The following is a description of a gene set: species: Mus musculus Mouse genes annotated to increased circulating tumor necrosis factor level (MP:0008553) retrieved from the Mouse Genome Informatics database via MouseMine Mouse Gene Set: MP_INCREASED_CIRCULATING_TUMOR_NECROSIS_FACTOR_LEVEL from publication Motenko H, Neuhauser SB, O'Keefe M, Richardson JE (PMID 26092688), and this is the list of marker genes: Nlrc3, Tbc1d23, Sod1, Lgmn (legumain), Hmgb1, Flt3, Wwp2, Dusp1 (dual specificity phosphatase 1), Apc, Mavs, Trp53, Ramp1, Marchf2, Tbk1, Cav1, Nod2, Slamf6, Osmr, Il10ra, Itln1, Prdx5, Tlr7, Hmox1, Fasl, Itgal, Map3k7, Tnfaip3 (NCBI Gene Id 21929), Egfr, Ikbkg, Slc2a6, Ash1l, Parg, Snrk, Nfkbia, Wasl, C1qtnf4 (NCBI Gene Id 77240), Sectm1a, Foxp3, Elavl1, Pcsk1, Ncoa3, Sh3bp2, Smpdl3b, Sting1, Hck, Tnf, Il18, Lat2, Traf2, Dusp11, Il10 (interleukin 10), Thbd, Fos, Tnfaip8l2, Tnfrsf1a, Brd2 (NCBI Gene Id 547337), Cyrib, Nfil3, Psmb10, Fitm2, Nfe2l2, Sirt3 (sirtuin 3), Ffar2 (NCBI Gene Id 233079), Prf1, Stk38, Unc93b1, Dusp22, Ldlr, Stat6, Ccl2, Trim8, Lyn (NCBI Gene Id 99963), Cd44, Lif, Cd209d, Cebpb, Snrnp40, Dnase2a, Rc3h1, Il27ra, Myd88 (myeloid differentiation primary response gene 88), Rnf146, Trem2, Hnrnpd, Rpl13a, Nlrp3, Mertk, Senp1, Zc3h12a, Mir146 (NCBI Gene Id 387164, microRNA 146), N4bp1 (NCBI Gene Id 97462), Stx11, Stat3, Tnfrsf1b, Zfp36, Rab27a, Ikbip, Trim38, Il6ra